The following is a description of a gene set: Double-strand break signaling. Pathway ID: N01439. Pathway type: Reference. Pathway class: nt06506 Double-strand break repair. Human Gene Set: KEGG_MEDICUS_REFERENCE_DOUBLE_STRAND_BREAK_SIGNALING Pathway Definition from KEGG: MRN == ATM == H2AX -> MRN+ATM+MDC1+H2AX == RNF8+HERC2+UBE2V2+UBE2N -> MRN+ATM+RNF8+MDC1+H2AX == L3MBTL2 == RNF168+UBE2V2+UBE2N+HERC2 == PIAS4 species: Homo sapiens, and this is the list of marker genes: HERC2 (NCBI Gene Id 8924), PIAS4, MRE11, H2AX, RNF8, RAD50, UBE2N, ATM, RNF168, NBN (NCBI Gene Id 4683), L3MBTL2, UBE2V2, MDC1